The following is a description of a gene set: Human Gene Set: RUBENSTEIN_SKELETAL_MUSCLE_SATELLITE_CELLS studied in species Homo sapiens from publication Rubenstein AB, Smith GR, Raue U, Begue G, Minchev K, Ruf-Zamojski F, Nair VD, Wang X, Zhou L, Zaslavsky E, Trappe TA, Trappe S, Sealfon SC (PMID 31937892), and this is the list of marker genes: GLUL, PPIA, EGR1, RARRES2, RPL19, RPL6, RPL41, CD63, APOC1 (NCBI Gene Id 341), PARK7, RPL36, GAPDH, PON2, MT1E, VDAC3, CLU, RPL14, DLK1, TPD52L1, TUBB, SMDT1, RPL28, ATP5F1D, ZFYVE21, AKR1B1, PAX7, UQCRB, H1-0, SNRPF, IER2, ATP5MC2, LSP1, MEST, RPL31, MDH2, RACK1, PYURF, RPL7, VAMP2, RPL10A, CSRP2, RPS26, CD9, S100A6, RPS9, UQCRFS1, RPL11, ALDOA, BEX4, RPS20, RAN, HEY1, HDAC2, SRSF3, RPS21, RPL21, RPS29, EIF3E, CST3, RHOB, RSL1D1, TUBB2B, RHOA (ras homolog family member A), HNRNPA0, U2AF1, S100A4, RPS3, CHCHD10, DUT, MT-CO3, RPS16, HNRNPA1, RPL10, MT-ND5, PMP22, ANXA5, RPL24, COPS9, RPL38, VDAC2, FOSB, RPLP2, FAM162A, RPL35, HSBP1, BEX3, BTF3, FUNDC2, RPL9, BANF1, WDR74, RPL5, NDUFS4, DBI, DUSP1, RPL18, RPS18, RPS10, TUBA1B, NAA20, COX7A2L, TMEM230, RPS27A, PPP1R14B, RPL7L1, JUN, ATP5MG, RPLP1 (ribosomal protein lateral stalk subunit P1), HSP90AB1, HSPD1, EIF3H, AK1, MIF, EDF1, PSMB7, RPS13, VDAC1, HIGD2A, RPS27, RPS15, SIRT2, RPS3A, CEBPD, RND3, RPS14, PDLIM4, EIF3L, SEC63, RPL37A, RPS2, COX4I1, PABPC1, RBM3 (NCBI Gene Id 5935), LMNA, RPL34, RHOBTB3, NDUFA5, RPL37, LSM5, COMT, NDRG2, GADD45GIP1, DDAH2, NHP2, RPL15, EIF4A1, STAC3, RPL30, PRDX6, FGL2, ATP5F1A, IGFBP5 (NCBI Gene Id 3488), ZFAS1, SDHC, ARL6IP5, CNBP, MYF6, NDUFB9, NACA, VIM, NDUFS5, RPL7A, MT-CO1, NPM1, MYC, RSL24D1, EEF1A1, TMEM123, SGCA, RPS23, HMGN1, HSPE1, CHCHD2, CCT4, ST13, MYF5, RBP1, MEG3, RPS24, RPL4, CRYAB, TSC22D1, LAMP2, RBMX, RPS7, RPL39, ATP5MF, TTC3, ZBTB20, ATP5MC1, TIMM13, EIF3D, EIF3K, UQCRH, RPS15A, RPL22L1, RPL29, CCT3, RPL32, HNRNPR, FAU, RPS25, EIF2A, VAPA, TUBA1A, RPL35A, RPS28, TCEAL9, EIF3F (eukaryotic translation initiation factor 3 subunit F), RPS19, MT1X, RPS4Y1, TOMM7, SPATS2L, RPSA, RPL23, CADM2, ALDH1A1, PTMA, CIRBP, JUND, RPL12, RPS6, SARAF (NCBI Gene Id 95251), RPL23A (NCBI Gene Id 6147), FOS, FXYD1, PDLIM3, EIF4A2, RPL13A, CCT8, APRT, NFIA, RPL27, RPS8, ATP5PO, GNAS, HADHA, COMMD6, RPL36A, SNHG32, PRDX3, DAG1, RPL22, RASD1, UXT, SGCE, EEF1D, TAF7, RPS4X, DES, HDDC2, SNHG8, EEF1B2, PEBP1, CXCL14 (NCBI Gene Id 9547), PPP1R15A, SBDS, MOCS2, HSPA8, SLC25A6, CNN3, MORF4L2, PRKX, ATP5MC3, DNAJC7, DARS1, RPL8, RPL26, ESF1, EEF2, HMGN2, RPL17, TPT1, TLE4, ZFP36, HNRNPDL, TRDN, EIF1, SPG21, CCN1, SNRPD2, NDUFA4, LDHB, RPL3, RPS12 (ribosomal protein S12), MRPL20, UBXN1, ARF4, SLC25A3, RPL18A, UBA52, IMPDH2, ESD, SPRY1, CHRNA1, RPS5, RPL13, SNRPE, BTG2, MICOS13, APOE, JUNB, SNRPD1, RPLP0, EPB41L4A-AS1, NOP53, RXRG, NDUFS6, EIF3M (NCBI Gene Id 63319)